The following is a description of a gene set: Human Gene Set: HP_GENERALIZED_AMYOTROPHY Generalized amyotrophy studied in species Homo sapiens Generalized (diffuse, unlocalized) amyotrophy (muscle atrophy) affecting multiple muscles., and this is the list of marker genes: MST1, MEGF10, SPEG, EXOSC9, TK2, SPTBN4, BAG3, PYROXD1, COL6A3, SELENON, POLR3A, SLC18A3, NOTCH2NLC, GPR35, TBK1, SGCD, PNPLA2, ACADSB, VCP, TUBA1A, BIN1, HNRNPA2B1, SCYL1, YARS2, C2orf69, SCO2, ACTA1, SLC16A2, NDE1, PGAP1, WARS2, MPV17, TCF4, MUSK, RNF170, RAPSN, TPM3, GMPPB, DOK7, OGDH (NCBI Gene Id 4967), PUS1, MGME1, KBTBD13, MYOD1, RYR1, SPTLC1, CARS1, COL12A1, DNA2, DNAJC19, VAMP1, TARDBP, SEMA4D, POMT1, TTN, MYH7, LMNB2, ADSS1, COL6A1, NUP88, FUCA1, HNRNPA1, PNPLA6, CNBP, SPG11, PIGA, SQSTM1, NAGA, DALRD3, RBM28, MAGEL2, NEB, KLHL41, SCN4A, KIF21A, LMNA, MYPN, UNC45B, FUS, LAMP2, POLG, COL6A2, ALDH18A1, DARS2, TWNK, CHCHD10, SLC52A2, TPM2, TRIP4